Given this list of marker genes Gbp2, Ifi47, Cd274, Gbp3, Arl4a, Slc35b1, Batf, Lin37, Zfp599, Gbp4, Gadd45b, Erap1, Stat1, Gzmc, Xrcc5, Iigp1, Serpina3f, Zfp938, Irgm2, here is a description of the gene set: Mouse Gene Set: CUI_ILC_IL18_RESPONSE_UP from publication Cui A, Huang T, Li S, Ma A, Pérez JL, Sander C, Keskin DB, Wu CJ, Fraenkel E, Hacohen N (PMID 38057668) studied in species Mus musculus Cytokines mediate cell-cell communication in the immune system and represent important therapeutic targets. A myriad of studies have highlighted their central role in immune function, yet we lack a global view of the cellular responses of each immune cell type to each cytokine. To address this gap, the authors created the Immune Dictionary, a compendium of single-cell transcriptomic profiles of more than 17 immune cell types in response to each of 86 cytokines (>1,400 cytokine-cell type combinations) in mouse lymph nodes in vivo. A cytokine-centric view of the dictionary revealed that most cytokines induce highly cell-type-specific responses. For example, the inflammatory cytokine interleukin-1β induces distinct gene programmes in almost every cell type. A cell-type-centric view of the dictionary identified more than 66 cytokine-driven cellular polarization states across immune cell types, including previously uncharacterized states such as an interleukin-18-induced polyfunctional natural killer cell state. Genes positively differentially expressed in cell type: ILC (innate lymphoid cell) upon treatment with cytokine: IL-18 in mouse lymph nodes in vivo.